The following is a description of a gene set: Combining with the neurotransmitter dopamine to initiate a change in cell activity. Mouse Gene Set: GOMF_DOPAMINE_NEUROTRANSMITTER_RECEPTOR_ACTIVITY studied in species Mus musculus, and this is the list of marker genes: Drd1, Drd2, Drd5, Drd3, Drd4